Given this list of marker genes Fau, Fos, Atf3, Hspa1a, Jun, Klf2, Hspa1b, here is a description of the gene set: Cytokines mediate cell-cell communication in the immune system and represent important therapeutic targets. A myriad of studies have highlighted their central role in immune function, yet we lack a global view of the cellular responses of each immune cell type to each cytokine. To address this gap, the authors created the Immune Dictionary, a compendium of single-cell transcriptomic profiles of more than 17 immune cell types in response to each of 86 cytokines (>1,400 cytokine-cell type combinations) in mouse lymph nodes in vivo. A cytokine-centric view of the dictionary revealed that most cytokines induce highly cell-type-specific responses. For example, the inflammatory cytokine interleukin-1β induces distinct gene programmes in almost every cell type. A cell-type-centric view of the dictionary identified more than 66 cytokine-driven cellular polarization states across immune cell types, including previously uncharacterized states such as an interleukin-18-induced polyfunctional natural killer cell state. Mouse Gene Set: CUI_CDC2_IL5_RESPONSE_DN studied in species Mus musculus Genes negatively differentially expressed in cell type: cDC2 (conventional dendritic cell type 2) upon treatment with cytokine: IL-5 in mouse lymph nodes in vivo. from publication Cui A, Huang T, Li S, Ma A, Pérez JL, Sander C, Keskin DB, Wu CJ, Fraenkel E, Hacohen N (PMID 38057668)